Given this list of marker genes RB1, rep, SARS coronavirus, complete genome, VHL, DDX5, ZCRB1, 1a, here is a description of the gene set: Reactome Pathway: Replication of the SARS-CoV-1 genome studied in species Homo sapiens The plus strand RNA genome of the human SARS coronavirus 1 (SARS-CoV-1) is replicated by the viral replication-transcription complex (RTC) composed of nonstructural proteins nsp3-nsp16, encoded by open reading frames ORF1a and ORF1b. Two RTC proteins, nsp8 and nsp12, possess 5'-3' RNA-dependent RNA polymerase activity. nsp12 is the main RNA polymerase, while nsp8 is thought to act as an RNA primase. nsp14 acts as a 3'-5' exonuclease, increasing the fidelity of the RTC. nsp14 also has the RNA capping activity and, in concert with nsp16, it caps viral plus strand and minus strand genomic and subgenomic RNAs, which confers stability to viral RNAs by enabling them to escape interferon-mediated innate immune responses of the host. nsp13 is an RNA helicase which is thought to melt secondary structures in the genomic RNA during replication and transcription. The plus strand genomic RNA is first used to synthesize the minus strand genomic RNA complement, which is subsequently used as a template for synthesis of plus strand viral RNA genomes that are packaged into mature virions. For review, please refer to Yang and Leibowitz 2015, Snijder et al. 2016, Fung and Liu 2019. part of: SARS-CoV-1 Genome Replication and Transcription